Given this list of marker genes Marchf8, Zbtb40, Ttyh1, Mettl16, Dynlt1b, Lsm14a, Tardbp, Snord1c, Kif24, Mdh2, Noa1, Huwe1, Btbd10, Phf12, Tab3, Pum3, Nudt2, Haspin, Snhg8, Mob1b, Chaf1a, Tmem79, Per1, mt-Tq, Akap11, Coq9, Smdt1, 4930579K19Rik, Capg, Supt5, Sugp1, Tcf25 (NCBI Gene Id 72298), Oasl1, Mau2, 5730522E02Rik, Gm12694, Ppp4r3b, Tmco1, Cenpt, Ncapg, Rbm39, mt-Tl2, Atf7, Cdc20, mt-Nd5, Cox11, Zzz3, Mre11a, Mapk14, Gm11399, Plscr4, Atraid, Mrpl57, Ank1, Mob1a, Rpp38, Kmt5b, Rfx1, Ergic2, Dguok, Neat1, H2bc18, Zfp566, Polr2b, H2bc15, 2810454H06Rik, Tent4a, Ssbp1, Polr2a, Tcf3, Sap18, Frmd8os, Dhx9, Hira, Rraga, Mir5133, Or51f23, Acot8, Rpl12 (NCBI Gene Id 269261), Acot9, Cyb5d1, Gm26590, Gm42935, Tmem134, Ube3a, Dars1, Eif4a3, Cenpb, Hnrnph3, Stip1, Cul5, Klf2, Tas1r1 (taste receptor, type 1, member 1), Hspa5, Mak16, 1700003G18Rik, Acaa1a, 1600023N17Rik, Nup58, 4833439L19Rik, Ampd2, B230354K17Rik, Supt16, Micu2, Rps7, Lamp1, Rab33b, Srsf10, Ighv5-19, Rabgef1, Rnf4, Gm36266, Pcmtd1, Wrap53, Rfesd, Styxl1, Ski, Ufd1, Idh3g (NCBI Gene Id 15929), Thada, Gid8, Eif5, Fth1, Sf3a2, Gm4189, 1600012H06Rik, Pik3r2, Slc39a7, Gm20186, Ska3, Gm22554, Erp29, Tipin, Marchf7, Get4, Atpsckmt, Gm14963, Mrpl40, Mrps23, Nop14, Creld2, Kazald1, Alg12, Txnip, Cnot3, Suv39h1, Qrich1, Micos10, 2810402E24Rik, Ubc, Or2g1, Mrpl45, Gm24027, Zcchc14, Dido1, Pcnt, Xpc, Cltc, Naa38, Smarcd2, Gm15441, Abhd18, Hmbox1, Gm23969, H2bc21, Setd1a, Stx4a, Khsrp, Vps4b, Copb2, Psmd5, Relch, 3110070M22Rik, Smg5, Mysm1, Adss2, Gm8357, Gm5619, Plekha4, Cdc5l, Spdl1, Gm12500, Agtpbp1, Cdc45, Snora24, Ddx20, Snhg16, Rps3a1, Ube2d3, Ssr4, Gdi2, Uhrf2, Gm12301, Rps19, Adnp, Thap2, Vmac, Nudt1, Zfyve27, Ino80, BC004004, Lrsam1, H2ac20, Wdr77, Tbc1d10b, mt-Tw, Slc39a9, Gpatch3, Asxl1, Gm15564 (NCBI Gene Id 102639045), Gm13879, Denr, Mir3077, Rpl7a, Snhg9, Slc6a6, S100a4 (S100 calcium binding protein A4), Pfkfb2, Sfi1, Zmym3, Csde1, H2ac15, Ankhd1, Tasor2, Ncapg2, Lyz2, Lsm8, Nktr, Mrps14, Gm17484, Duxf1, Asph, 1110004F10Rik, Slc15a4, Gpr19, Ppm1g, Ddit3, 5430416N02Rik, Rbm26, Wdr73, Srcap, Grk4, Gm10222, Scamp5, Malat1, Lyrm7, Prpf4, Pop5, Tubgcp5, Ttc14, Ssmem1, Snora64, Eif5b, Ccl3, Nol9, Cdk12, Etf1, Lsm3, Ndufa7, Nsun3, Puf60, Arf3, Septin7, Stk38l, Rnd2, Nasp, Prdx1, Glce, 4930539J05Rik, Matr3, Dbr1, Slc35b4, Zfc3h1, Pbld2, Fam76a, Mpc2, Slc5a6, Psmb2, Jpt1, mt-Ts2, Zfp414, Dpy30, Hspa4, Ubr3, Lrif1, Rbm15, Hsbp1, Atp5f1c, Snora78, Cdc26, Cct8, Txndc9, Myef2, Rnpc3 (RNA-binding region (RNP1, RRM) containing 3), Ttc32 (tetratricopeptide repeat domain 32), Dis3, Vdac3, Smndc1, Gm5773, Ppp1r15a, Gm28047, Zmynd8, mt-Th, Tmem129, Pign, 3110083C13Rik, Cct5, Ptgr2, Med22, Gm27011, Slc25a4, Rxrb, Ncoa4, Abi1, Ehd1, Dctn2, Gm15927, Mbtps1, Tmem116, Baz2b, Ireb2, Naa35, Tspyl1, Edrf1, Dnajb4, Mvb12b, Agl, Mad1l1, Spsb3, Exo5, Icmt, Mms22l, Ptpn4, Rc3h2, Cmtr1, Herc1, Crebzf, Saysd1, Dnajc27, Zswim3, Tacc3, Stxbp4, Dlx4, Rpl26, Ciapin1, Ddhd2, Camk2d, Nubp2, Exosc10, Plekhj1, Mir6236, Gm16124, Bud13, Atf2, Map3k7, Banp (BTG3 associated nuclear protein), Npm1, Tmem209, Rps2, Atp5pb, Rpl10a, Rps28, Fadd, Erh, Fubp1, Ercc6l2, Aip, Luc7l2, Thap11, Afg2a, Ankfy1 (ankyrin repeat and FYVE domain containing 1), Ndufa11, B130034C11Rik, Gm22979, Chuk, 2900037B21Rik, Ralbp1, Sec23ip, B230219D22Rik, Kin, Dcaf6 (DDB1 and CUL4 associated factor 6), here is a description of the gene set: Mouse Gene Set: NFAT5_TARGET_GENES species: Mus musculus from publication Yevshin I, Sharipov R, Kolmykov S, Kondrakhin Y, Kolpakov F (PMID 30445619) Genes containing one or more binding sites for (Nfat5) in their promoter regions (TSS -1000,+100 bp) as identified by GTRD version 20.06 ChIP-seq harmonization.